Given this list of marker genes TNIK, RPS7, UBE3A, UBA2, BTRC, IGF1, GTF2H1, CEP295, BRMS1, CAMLG, GTPBP4, HUWE1, CCDC88A, RELA, HSPA5, RAMP1, RAPGEF2, SFN, PRKAA1, ADIPOQ, UBE2V2, IVNS1ABP, HDAC4, CDC6, NSD1, GNL3, C9orf72, KDR, SIAH2, TRAF4, RABL3, MTBP, CAB39, RAB3GAP1, FIRRM, BMP4, SPDYA, FBXO4, TLR3, FGFR1, LYN, SERTAD1, PILRB, SYNPO2, UBE2C, NDFIP2, IL15, ERRFI1, IL34, CCNYL1, CCAR2, SAE1, DMTN, KDM1A, APOE, PDCD10, PFN2, CRY1, PDGFRB (NCBI Gene Id 5159), FBXO2, FKBP8, ITLN1, IL12A, P3H1, ETAA1, ACP4, MST1, FLT3, SKP1, CAV1, DEPTOR, UBE2K, PIN1, CDK5RAP1, CACTIN, RAP2A, CDKN2A, TAF1, TAF7, DBI, ROPN1, CHP1, CHFR, ZFP91, ADCYAP1, GABARAP, MAP2K1, HGS (hepatocyte growth factor-regulated tyrosine kinase substrate), PRKAA2, TSG101, SOCS4, INSM1 (NCBI Gene Id 8196), PSMD10, PTPN1 (protein tyrosine phosphatase non-receptor type 1), AIDA, COPS6, CAMK1, DIPK2A, SIRT7, FZR1, CCNK, TERF2IP, CNOT9, PIK3R5, TNFSF15, EFNA5, ADAM17, DIRAS2, CDKN1C, KLF15, WNT5A, MAD2L2, CDKN1B, HHATL, CDYL, EP300, PER2, PIAS4, DERL1, IL31RA, MST1R, MTA1, INAVA, TGFBR1, HRG, PRMT3, TCF25, DBNDD2, AKT1S1, CDK5RAP3, FBH1, DUSP7, MAP3K7, PIM1, PINX1, ANGPT1 (angiopoietin 1), RARRES2, DIP2B, GSK3B, SMO, MMD2, FLOT1, CDC14B, TNFRSF10A (NCBI Gene Id 8797), UBE2L3, TNFRSF18, LEP, ECT2, BIRC8, UBB, RB1, SNX9, MALT1, ENPP2, DNAJC3, BCL10, PELI2, SPHK1, CLSPN, MEN1, XBP1, MAP2K3, CDC37, MYCBP2, BAG5 (NCBI Gene Id 9529), KAT5, MARCHF7 (NCBI Gene Id 64844), MAP3K4, EREG, PKMYT1, OGT, CBLB, GSK3A, RALB, SRCIN1, MAP3K10, TNFAIP3, FLCN, CCNY, ARRDC3, PHF23, FAM20A, FGFR3, BIRC3 (NCBI Gene Id 330), HES1, SENP2, RPL11, CD300A, TANK, BLM, SPOPL, NPM1, ROPN1B, PARP14, PTTG1IP, HSPA1B, NRG1, GPS2, TNFRSF10B, HSP90AA1, TRAF6, KSR1, PPP1R15B, DIP2A, ARAF, MAPK8IP1, PRKCH, ROCK2, PRKCG, NSMCE3, ATG7, IRGM, COPS9, SFRP2, TARBP2, MAGEA2, XIAP, DAXX, CIB1, CHI3L1, XRCC5, CEP78, RAP1A, IL6, PARK7, CDK5R2, FBN1, CARD10 (caspase recruitment domain family member 10), MIR101-1, ARNT, ARHGEF5, PRKCE, DNAJA3, SLC51B, PIK3R6, UVRAG, CDC25A, GOLGA2, TNIP1, RAP2C, HEG1, DRD4, DOK7, RIPK1, IL20, SAMSN1, SYAP1, DUSP1, AIMP2, FBXW7, ELANE, EPAS1, CDK5, DDRGK1, RPS3, MT3, HSP90AB1, CTF1, IBTK, SASH1, ERCC6, RBX1, CCNT1, UFL1, SVIP, PKIA, DDX3X, FBLN1, CNOT7, ABL1, CTNNB1, TRIM27, LRRK2, GPRC5A, LTF, KLHL31, BEX2, LAT, AMER1, TNFSF18, NMI, PIAS1, TOLLIP, EPHA7, PROM2, STOX1, KIF14, TNF, RIPK3, TLR6, DYNAP, WNK1 (WNK lysine deficient protein kinase 1), BIRC7, PDCD4, TNK2, AGAP2, SNX6, SMG8, GNL3L, PAK2, ATG14, WDR48, ODAM, MMP9, U2AF2, TPD52L1, RAF1, VPS28, KIT, KNDC1, ATG5, PIBF1, UBE2N (NCBI Gene Id 7334), SOCS5, JAK2, PIK3C3, FGR, C3, BANK1, GCLC, IL18, RACK1, TAOK3, ACVR2A, CCNG1, SRC, STUB1, COPS5, VPS25, DEFB114, AXIN1, USP44, PLXNB2, ADARB1, PHIP, THY1, FBXO5, RWDD3, GAS6, SFRP1, RASGRP1, MGAT4D, ERN1, CDKN1A, PTPRJ, CENPE, PIH1D1, ITGB2, MAP3K5, LIMCH1, TSPYL5, DTX3L, FGF16, HMGA2, UBE2S, SH3RF2, VCP, DCUN1D3, FANCM, PABPN1L, BEX4 (NCBI Gene Id 56271), BEX3, ROPN1L (NCBI Gene Id 83853), FAM161A, STK11, CEP85, PARP10, GPER1, NDUFS4, SEMA4D, STK38, MAP4K2, PTEN, NEDD9, KDM4D, NGF, DIRAS1, CEACAM1, BMP2, NDFIP1, LIF, GPS1, PYCARD, S1PR2, SIRT1, ERBB4, RPS2, ERBB2, RAP2B, STRADB, PRLR, GPRC5B, NXN, HAMP, LILRA5, CEMIP, PDCL3, CHMP6, MUSK, ARL2BP, HIF1A, TENM1, HSPB1, S100A12, UBQLN1, DCUN1D2, DCUN1D5, HMG20B, HDAC8, SIRT2, HERPUD1, PPM1E, ADAR, MAPK9 (NCBI Gene Id 5601), COPS7A, PRKN, NNMT, ZGPAT, FAM107A, TXN, BMAL1, WBP1L, TRIB2, TRAF3IP1, CDK12, MVP (NCBI Gene Id 9961), FSCB, TRIM44, INCA1, BAG2, MAP3K11, CDC25C, TRIB1, PLAUR, CD74 (CD74 molecule), CENPS, PTPN2, WNK3, CEP43, COPS8, MAPT, RPL23, PARD3, GSKIP, ITCH, UBE2B, PTPN22, PDCD6, LACRT, SPRTN, FGF10, TRAF2, TARDBP (NCBI Gene Id 81927), USP4 (NCBI Gene Id 7375), CSPG4, CCNE2, TAB2, CCNT2, IL11, HIPK3, ABI1, BMI1, PEF1, CREBL2, COMMD1, TSPO, HMG20A, PDGFB, BRAF, BEX1, BRAT1, PELI1, FGF7, AGT, CALCA, N4BP1, ISG15, THPO, MAD2L1, TRIM6, PRKDC, CUL3, MIR138-1, FRY, UBE2V1, FYN, NLRP2B, MUL1, WDFY2, FGF19, CD4, EGF, RPL5 (ribosomal protein L5), PPIA, IL21, RTRAF, LCP2, CAPN3, PTK2B, PAQR3, MAPK1 (mitogen-activated protein kinase 1), CACUL1, NOP53, OSM, FGF2, SNF8, EGFR, TCIM, HDAC3, TGFB1, FLT1, SPSB4, PTPN13, DNAJA1, CADM4, STRADA, CCDC134, ARRB2, ASPSCR1, COPS3, DNAJB2, PPIB, TPX2, RASD2, EPM2A (EPM2A glucan phosphatase, laforin), CDK5R1, BCCIP, RAB3GAP2, UBXN2A, CORO1C, PARP9, FER, RAC1, FOXF2, PIAS3, ARHGEF2, TICAM1, APC, RCHY1, PLAA, CAMKK2, NOD2, CD80, ZNF268, OTUD4, FGF18, CARD14, ABCA2, TBC1D7, TRIB3, PINK1, RASSF2, TFAP4, HERC5, STK4, NPTN, ZC3H12A, RSPO1, IFNL1, FAXDC2, DCUN1D4 (NCBI Gene Id 23142), RASIP1, TTC36, SVBP, RNF180 (NCBI Gene Id 285671), GADD45A, FGF1, TOM1L1, PRKCD, PTK6, NEK10, CSF1R (NCBI Gene Id 8156), ARRDC4, RGS14, TPPP, UBXN1, CLIP3, PIK3CG, RASSF5, FN1, TBX1, NPPA, ZBED3, PLK1, UBE2D1, FXYD1, DCUN1D1, ZFYVE28, NHERF1, CDC20 (cell division cycle 20), FLT4, FANCI, VEGFA (NCBI Gene Id 7422), LAPTM5, HSPA1A, MYDGF, IGFBP3, HLA-DRB1, RNF111, PTK2, MARCHF6-DT, INPP5F, ALS2, CEP63, COPS7B, DIRAS3, PDGFA, ADGRB1, ADCY8, BIRC2, YWHAG (NCBI Gene Id 96443), FBXO33, XRCC6, SERPINB3 (NCBI Gene Id 96249), AKTIP, MOB1B, RIPK2, ITGB1BP1, SEPTIN4, ANGPT4, MAGEC2, CNKSR3, EFNA1, MRNIP, NT5DC2, EGR1, MINAR1, WFS1, DDR2, ACER2, CASS4, IFNG, LATS1, MMD, CDKN3, EZH2 (NCBI Gene Id 392834), PRICKLE1, CNTF, LATS2 (NCBI Gene Id 95108), TRIM21, MACROH2A1, NHLRC1, SQSTM1, CDK2AP1, THBS4, RASSF1, TSPYL2, COPS2 (NCBI Gene Id 9318), UNC119, SKP2, WARS1, SPRY2, CRIPTO, SESN2, PTPRC, WASHC1, RHOA, STAT2, AKT1, ARRB1, RALBP1, HSPBP1, PAXIP1, COPS4, KLHL40, NIBAN1, CRTAP, PRR5L, FKTN, MAP2K2, JTB, VEGFB, MAGEA2B, SLIT2, CENPX, here is a description of the gene set: Any process that modulates the frequency, rate or extent of the covalent alteration of one or more amino acid residues within a protein. Human Gene Set: GOBP_REGULATION_OF_PROTEIN_MODIFICATION_PROCESS studied in species Homo sapiens